Given this list of marker genes Grb2, Irs2, Shank3, Lat, Spata2, Crk, Frs2 (fibroblast growth factor receptor substrate 2), Frs3, Gnb5, Sh2d3c, Gnb2, Shb, Ptpn11, Sorbs1, Sh2b2, Lrrk2, Pxn (NCBI Gene Id 19303), Sh2b1 (NCBI Gene Id 77601), Gnb1, Akap12, Shank1, Stap1, Cdh5, Dok2, Gab2, Ldlrap1 (low density lipoprotein receptor adaptor protein 1), Tradd, Shc1, Grb10, Gnb3, Rgs14, Gnb4, Irs1, Homer2, Magi2, Mapk8ip3 (NCBI Gene Id 30957), Spag9, Sh2b3, Nup62, here is a description of the gene set: studied in species Mus musculus The binding activity of a molecule that provides a physical support for the assembly of a multiprotein receptor signaling complex. Mouse Gene Set: GOMF_SIGNALING_RECEPTOR_COMPLEX_ADAPTOR_ACTIVITY